Given this list of marker genes SRSF5, SRSF3, SEC13, DDX39B, NUP133, NUP85, THOC2, NUP214, WDR33, DDX39A, SRSF4, DHX38, NUP88, NUP210, THOC3, POM121, CPSF3, TPR, RNPS1, NUP37, NUP62 (NCBI Gene Id 51551), CPSF2, RANBP2, THOC5, UPF3B, NUP205, CPSF4, THOC1, U2AF1L4, NUP54, U2AF2, LUZP4, POM121C (POM121 transmembrane nucleoporin C), CDC40, SRSF9, MAGOH, SRSF7, GLE1, NUP42, NUP153 (NCBI Gene Id 9972), SRSF11, NUP160, SRSF2, SLU7, NUP107, NCBP2, NUP155, SLBP, ALYREF, NUP58, MAGOHB, FYTTD1, NXT1, NUP98, RBM8A, SRSF6, RAE1, NXF1, EIF4A3, SRRM1, NUP188, THOC7, SRSF1, U2AF1, CHTOP, POLDIP3, FIP1L1, NCBP1, SARNP, SYMPK, ZC3H11A, CASC3, NUP35, NDC1, THOC6, AAAS, NUP50, NUP93, SEH1L, EIF4E, CPSF1, NUP43, NXF2, here is a description of the gene set: studied in species Homo sapiens Reactome Pathway: Transport of Mature Transcript to Cytoplasm Transport of mRNA through the Nuclear Pore Complex (NPC) is a dynamic process involving distinct machinery and receptor subsets. The separation of the two compartments and the regulation of this transport provide spatial and temporal control over mRNA expression and ultimately control over translation. It should be noted that mRNA export does not rely on a specific motif in the mRNA molecule, but rather transport appears to be coupled to processing and regulation. The specific proteins that are bound to the mRNA determine when it will be transported to the cytoplasm. This limitation insures that transport overwhelmingly favors transport of fully processed mRNA molecules. part of: Processing of Capped Intron-Containing Pre-mRNA